Given this list of marker genes Ube2n, Rad52, Rnf138rt1, Rad50, Dna2, Exd2, Rbbp8, Rnf138, Blm, 4930447C04Rik, Helb, Ube2v2, Helq, Spo11, Setmar, Mre11a, Brip1, Atm, Nbn, Smarcad1, Slx4 (SLX4 structure-specific endonuclease subunit homolog (S. cerevisiae)), here is a description of the gene set: species: Mus musculus The 5' to 3' exonucleolytic resection of the DNA at the site of the break to form a 3' single-strand DNA overhang. Mouse Gene Set: GOBP_DNA_DOUBLE_STRAND_BREAK_PROCESSING